The following is a description of a gene set: studied in species Mus musculus electronically inferred by orthology from the curated human pathway This event has been computationally inferred from an event that has been demonstrated in another species.<p>The inference is based on the homology mapping from PANTHER. Briefly, reactions for which all involved PhysicalEntities (in input, output and catalyst) have a mapped orthologue/paralogue (for complexes at least 75% of components must have a mapping) are inferred to the other species. Reactome Pathway: Formation of Incision Complex in GG-NER part of: Global Genome Nucleotide Excision Repair (GG-NER), and this is the list of marker genes: Gtf2h2, Cul4b, Xpc, Ubb (ubiquitin B, NCBI Gene Id 22187), Ube2n, Gtf2h4, Chd1l, Ercc4, Rnf111, Ercc3, Xpa (xeroderma pigmentosum, complementation group A), Sumo1, Ccnh, Usp45, Ddb1, Cul4a, Rpa1, Ercc2, Ercc1, Rps27a